The following is a description of a gene set: from publication Amit I, Garber M, Chevrier N, Leite AP, Donner Y, Eisenhaure T, Guttman M, Grenier JK, Li W, Zuk O, Schubert LA, Birditt B, Shay T, Goren A, Zhang X, Smith Z, Deering R, McDonald RC, Cabili M, Bernstein BE, Rinn JL, Meissner A, Root DE, Hacohen N, Regev A (PMID 19729616) mouse primary BMDCs were stimulated with tlr ligands and gene expression changes were profiled on Affymetrix arrays Genes down-regulated in comparison of control dendritic cells (DC) at 24 h versus those stimulated with Gardiquimod (TLR7 agonist) at 24 h. studied in species Homo sapiens Human Gene Set: GSE17721_CTRL_VS_GARDIQUIMOD_24H_BMDC_DN, and this is the list of marker genes: PLA2G2D, TMEM199 (NCBI Gene Id 170473), PUM3, ANXA5, AP3M1, PIK3CG, ARHGDIB, UPP1, IGSF9, TMED7, PFDN2, ABCE1, SLC41A2, ALG2, MARCHF5, DRG2, TXNDC5, MEMO1, UFSP2, GTF2E2, SSX2IP, ZDHHC5, NCBP1, TUBA1A, PON3, NUP50, MTMR14, NAA30, LZTS2, ZCCHC3, NQO1, PLEKHA3, TBK1, RARS1, SEC24D, AUTS2, MMP12, RAP2A, HDAC1, THOC1, PPP2R3C, TMEM39A, DNAJB11, PLA2G12A, ALDH7A1, PSMB7, FKBP1A, C14orf119, SRSF7, MOB4, PAPLN, CMTR1, EMC7, HSPA4, KDR, MMP14, PSMB9 (proteasome 20S subunit beta 9), RIPK2, ERP44, ABRACL, CCDC107, HNRNPAB, RNF126, FZD5, PSMA2, MRPS2, TMEM100, PLSCR1, CYBB, PSMD5, BRCC3, MX1, TDRD7, GPR155, KATNBL1, SLC35G6, HAT1, NSG1 (NCBI Gene Id 27065), PTPN11, QSER1, NMD3, GORASP1, TRMT112, FASTKD5, GABPB1, CLMN, PRG2, UBE2O, PRMT7, TASOR2, PPBP, SPTB, HNRNPA3, HCLS1, SPATS2, MDH2, ARCN1, RP2, CTSK, ALPK2 (alpha kinase 2), DACH1, ZNF146, DERL2, TP53I13, THRSP, ZNG1B, PTPN1, NUP43, DUSP15 (dual specificity phosphatase 15), PARP14, REXO2, FBXW11, BBLN, DNAJC10, FST, IFT57, RRN3, RBM10, IER3, EIF2S2, CALCOCO2, LRRC59, CWC27, LIMD2, ARHGAP21, STAT5A, CES3, DNAJC3, UBE2S, GINM1, WDR43, CCL13, ZMYND19, CSDE1, SLC39A13, AHR, NOXO1, CCDC120, WDFY3, MRPL52, IRGM (NCBI Gene Id 345611), USP10, PTCD3, IL15RA, PPP2R1A, CD47, TAGLN3, NDP, PFKP, TMEM185A, RAB32, PSMC4, NRG4, ME1, USO1, TNFSF9, CYBC1, UBR2, SFXN1, SEC23A, NUDCD1, MGST2, RBM19, CST7, ZMYM1, PA2G4, GUCD1, PRPF3, NEK1, KCNN4, AGRN, TBX21, GMPPB, FKBP4, PXMP2, SEPTIN7, METTL6, CPD, ERAS, TMEM208, HTR2B, ZC3H12A, RWDD4, USP25, ACOT12 (NCBI Gene Id 134526), SLC7A5, KLK4, BFAR, SOCS4, ZNF672, NUDC, SSBP3, ABI1, RAD18, CHIC2, GRK2, CCT2, CFL1, PPIC